The following is a description of a gene set: Binding to a class I major histocompatibility complex. Human Gene Set: GOMF_MHC_CLASS_I_PROTEIN_COMPLEX_BINDING studied in species Homo sapiens, and this is the list of marker genes: CD160, KLRC1, KLRD1, KLRC2, CD8A, TAPBPL, TAPBP